Given this list of marker genes Atp2b1, Atp6v1a, Atp2c2, Abcb8, Cpox, Atp6v1c2, Uqcrh-ps1, Cox5a, Ndufs8, mt-Nd4, Atp6v1f, Abca7, Atp5f1e, Atp2a1, Abcc3, Kcnj11, mt-Co3, Abca12, Atp1a3, mt-Co1, mt-Nd2, Tmem94, Atp13a5, Abcc1, Abcc4, Abcc8, Cox7a1, Atp1a2, Abca5, Tap1, Abcc9, Atp6v0a1, Ndufa10, Abcg5, Atp7a, Ndufs1 (NCBI Gene Id 74755), Atp6v0d2, Atp6v1g1, Abca3, Atp2a2, Abcd3, Atp6v0c, Abca8a, Ndufs4, Atp1a4, Atp6v0e2, mt-Nd3, Atp6v0a4, Abcb1b, Abcc6, Atp6v1c1, Abcg1, Anxa5, Atp6v1e1, Abcg4, Ralbp1, Abcb10, Atp5mg (ATP synthase membrane subunit g), Atp13a1, Atp4b, Atp1b2, Atp7b, Ndufv2, Atp4a, Abcg2, Abca13, mt-Nd1, mt-Nd6 (NCBI Gene Id 17722), Ndufa2, Atp6v1b1, Ndufs3, Atp2c1, Abcb4, Kcnj8 (NCBI Gene Id 16523), Atp6v1d, Atp5f1b, Abcb11, Abca17, Bcs1l, Abcg8, Abcd2, Cyb561d2, Nnt, Atp2a3, Abcc2, Abcc12, Abcb9, Abcd4, Atp6v0b (NCBI Gene Id 66370), mt-Nd5, Abca16, Ipo8, Atp13a2, Cyb561d1, Abca6, Atp6v1b2 (ATPase, H+ transporting, lysosomal V1 subunit B2), Cox4i2, Cyb561a3, Atp1b1, Cftr, Abca14, Atp13a4, Atp6v1g3, Abcc10, Atp6v1h, Atp2b3, mt-Nd4l (mitochondrially encoded NADH dehydrogenase 4L), Ndufs7, Abcg3, mt-Cytb, Abca4, Uqcrh, Atp6v0d1, Uqcrfs1, Atp1a1, Abcb1a, Cybrd1 (NCBI Gene Id 73649), Surf1, Abcb5, Atp2b4, Atp6v1e2, Abcd1, Abca8b, Atp6v0e, Abcc5, Cyc1 (NCBI Gene Id 66445), Abca2, Abca1 (ATP-binding cassette, sub-family A member 1), Atp6v1g2, Abcb6, Tap2, Atp6v0a2, Abcb7, Atp1b3, Abca9, Ndufb7, Atp13a3, Abca15, mt-Co2, Atp2b2, Ndufv1, Tomm20, Ndufs2, Atp12a, here is a description of the gene set: studied in species Mus musculus Mouse Gene Set: GOMF_PRIMARY_ACTIVE_TRANSMEMBRANE_TRANSPORTER_ACTIVITY Enables the transfer of a solute from one side of a membrane to the other, up the solute's concentration gradient, by binding the solute and undergoing a series of conformational changes. Transport works equally well in either direction and is powered by a primary energy source. Primary energy sources known to be coupled to transport are chemical such as ATP hydrolysis, redox energy and photon energy.